The following is a description of a gene set: The portion of the plasma membrane at the lateral side of the cell. In epithelial cells, lateral plasma membranes are on the sides of cells which lie at the interface of adjacent cells. species: Mus musculus Mouse Gene Set: GOCC_LATERAL_PLASMA_MEMBRANE, and this is the list of marker genes: Cldn7, Slc6a9, Fgf13, Dsg1b, Cldn4, Dlg1, Vangl1, Dvl1, Gna12, Cldn13, Gjb2, Atp1a1, Mark2, Gjb1, Scn5a, Numa1, Ocln, Iqgap1, Cldn15, Ctnnb1, Slc12a2, Rab13, Ppp2r1a, Mtcl1, Dvl2, Atp1b1, Gja1, Sptan1, Dsg1c, Bves, Epcam, Erbb3, Abcc1, Cdh1, Myo1a, Dsg2, Ptpro, Slc16a1, Nkd2, Ank3, Slc16a3, Cldn3, Iqgap3, Axin1, Vangl2, Nsg1, Akap7, Cldn1, Mpp4, Fzd3, Slc22a1, Myh9, Abcc6, Ceacam2, Apc, Anxa1, Ceacam1, Mpp7, Drd2, Slc26a5, Arl2, Atp1b2, Coro1c, Dsg1a, C1qtnf5, Tacstd2, Gpsm2, Cldn18, Cldn5, Tbcd (tubulin-specific chaperone d), Pkd1, Jup, Slc26a7, Myo1c, Prickle2, Cldn12, Atp6v1b1, Kcnb1